The following is a description of a gene set: Human Gene Set: GOCC_CHROMAFFIN_GRANULE species: Homo sapiens Specialized secretory vesicle found in the cells of adrenal glands and various other organs, which is concerned with the synthesis, storage, metabolism, and secretion of epinephrine and norepinephrine., and this is the list of marker genes: ANXA7, DBH, CLU, CHGA, SYT1, SLC17A9, DNAJC5, PENK, DNM1, SRI, ATP8A1, CTSL, CYB561, SYT2